The following is a description of a gene set: Human Gene Set: HP_TIBIAL_BOWING Tibial bowing A bending or abnormal curvature of the tibia. studied in species Homo sapiens, and this is the list of marker genes: SOX9, CYP27B1, SLC34A3, MEG3, ENPP1, P3H1, COL1A2, PDGFRB, GORAB, PCNT, DYM, SATB2, SETBP1, DLK1, CYP2R1, CILK1, COL1A1, RTL1, DMP1, MMP13, RMRP, CHST3, CLCN5, PCYT1A, CLTCL1, FIBP, FLNB, FGFR3, PHEX, LRP5, COL10A1, FLNA, LIFR, FN1, COL11A2, CCN2, CPLANE1, SMOC1, VDR, SHOX, COL2A1, SERPINH1